Given this list of marker genes CC2D1A, WDR83OS, RBP1, FGF22, APOOL, BCKDHB, NASP, UGDH, ATP5PO, PDCD5, SS18L2, SLC4A7, ANKRD55 (ankyrin repeat domain 55), CNOT7, SDF2, GMPS, ZNF350, E2F6, BTF3P12, NELFE, CPSF6, APBA1, POLR2F (RNA polymerase II, I and III subunit F), ATP10A, H1-4, SNRNP35, ZNF14, CCDC47, CDK18, COMMD9, RAE1, OVOL3, DCXR, IZUMO4, PRPF31, ZNF385D, PUS3, FUT4 (fucosyltransferase 4), SNRPD3, RPL38, CASP3, RPL11, CINP, PITPNA, GGCT, NDUFAF4, ASL, TRIOBP, NUDT6, COX7A2, DCLRE1A, SHQ1, TKFC, RPS16, VAPB, TPP2, MRPS16, FAM174C, TEKT2, UFD1, TAF5L, RGS9, NDUFAF1, ORC3, TNFRSF11B, GNAT1, PLD1 (NCBI Gene Id 5337), PAK1IP1 (NCBI Gene Id 55003), LTBR, MAD2L1BP, IRAK1, HSPA14, NRDC, TRMT12, PTDSS2 (phosphatidylserine synthase 2), ATP5MC3, TCP1, TRIM17, STRAP, RNF138, SEC11A (SEC11 homolog A, signal peptidase complex subunit), NDUFA6, MTMR8, TXNRD2, ATP6V1B1, LINC01565, IPPK, GALE, ZC3H15, RAB9BP1, LRP3, LDHB, CEP43, CBLIF, UQCRC2, CLPP, METTL5, EDC4 (enhancer of mRNA decapping 4), DNAJC1, FERMT2, OR2F1 (NCBI Gene Id 26211), SHOX2 (NCBI Gene Id 6474), AATF, VPS37B, CAP2, MYG1, STX3, INTS1, SMAD2, CTDNEP1, ULK4, MAPKAPK5-AS1, TRPC7, CAV1, PSMB4, CPN2 (NCBI Gene Id 285280), UBE2A, KLHL7, C9, RPL19, GNG5, HIC2, MTIF2, HSF2, ACHE, CCT7 (NCBI Gene Id 10574), ENOX2, DOK1, FAF2, COQ6 (NCBI Gene Id 51004), RPL28, HIRIP3, SNRPD2, EXOC3, DNAJC15, IMP3, COX5A, DCAF1, UQCC1, GUCY2F (NCBI Gene Id 2986), FTCD, RPL36, OSMR, PSMB10, MMP3, WDCP, MRPS7, CUL2, MCF2L-AS1, JPT1, RASSF8, NUDC, ZNF432, SIVA1, PABPC3, CRADD, MRPS34, SEM1, PSMA7, AURKAIP1, EZH2, CAPN11, EXOSC7, FBXW7, POU2AF1, SOAT2, NDUFS2, HINFP, NACA, PSMD2 (proteasome 26S subunit ubiquitin receptor, non-ATPase 2), UTP11, CDHR2, LINC01711, RIC8A, RPS8, EEF1A2, MXD3, NAALAD2, UBA2 (NCBI Gene Id 10054), CARD9, CDKN2D, PCMT1 (NCBI Gene Id 5110), FAAP24, NDUFS7, TRPV2, TRIM24, NSF, THADA, TRIB3, RBP4, CCS, NSDHL, MRPS31 (mitochondrial ribosomal protein S31), MCUR1, NUP62, here is a description of the gene set: Genes down-regulated in comparison of NK cells stimulated with IL2 at 16 h versus NK cells stimulated with IL15 at 16 h. species: Homo sapiens Human Gene Set: GSE22886_IL2_VS_IL15_STIM_NKCELL_DN from publication Abbas AR, Baldwin D, Ma Y, Ouyang W, Gurney A, Martin F, Fong S, van Lookeren Campagne M, Godowski P, Williams PM, Chan AC, Clark HF (PMID 15789058) Immune cell-specific expression is one indication of the importance of a gene's role in the immune response. In order to identify such patterns, we set out to broadly profile gene expression in a variety of immune cells.